Given this list of marker genes AFF4, PCDHGA7, PCDHGC5, PCDHGB4, FANCE, SCN4B, NCOA1, ZNRF3, PCDHGA5, ZBTB7C, USF3, COBL, PCDHGA6, ELMO2, PCDHGB1, PCDHGB2, FGD6, TRIM66, BCO2, PCDHGA11, PCDHGA12, PCDHGC4, PCDHGB5, SYNPO2, CYB5R2, PCDHGC3, SFR1, RAP2C, DLGAP4, FAH, BIRC6, AGPS, SPECC1L, TUFT1, TRIM32, PCDHGA8, PCDHGB6, PCDHGA9, SH3BP1, STYXL2, ACAT2, MID1, PCDHGA10, SLC39A9, MVB12B, PPP1R10, MTHFD2L, FBRS, IP6K1, ILDR2, PCDHGA2, PCDHGA4, MECP2, DNASE2, RAD23B, PDRG1, SENP1, AAK1, IGF1R, KCNMB2, LRRC17, FMNL2, MTCL2, PCDHGA1, IBA57, CNIH1 (cornichon family member 1), BMF, CCL28 (NCBI Gene Id 56477), E2F5, PCDHGB7, ZNFX1, SHISA6, TNFSF15, ELFN2, PCDHGA3, H3-3B, C11orf87, RIPOR1, PCDHGB3, here is a description of the gene set: Human Gene Set: MIR1233_3P studied in species Homo sapiens from publication Chen Y, Wang X (PMID 31504780) Genes predicted to be targets of miRBase v22 microRNA hsa-miR-1233-3p in miRDB v6.0 with MirTarget v4 prediction scores > 80 (high confidence targets).